Given this list of marker genes PTPRF, TRIO, PTPRE, PTN, FRS2, PTPRU, PTPRD, here is a description of the gene set: The series of molecular signals initiated by an extracellular ligand binding to a receptor on the surface of the target cell where the receptor possesses protein tyrosine phosphatase activity, and ending with the regulation of a downstream cellular process, e.g. transcription. Human Gene Set: GOBP_CELL_SURFACE_RECEPTOR_PROTEIN_TYROSINE_PHOSPHATASE_SIGNALING_PATHWAY species: Homo sapiens